Given this list of marker genes ZBTB25, BCKDHB, SLC23A2, HSD3B7, SLC18B1, SIAE, HNRNPA1, ZNF330, REXO2, CSF2, PAQR3, LECT2, TEX261, ST8SIA6, SPTSSA, RTP4, MRFAP1L1 (Morf4 family associated protein 1 like 1), GPR18, SLX4IP, SLC35G1, ZDHHC2, CDC20, PWWP2A, NCOA7, NEU3, BICD1, CSTF2, GJB2, KIF26A, PPM1L, DNAAF10, HNRNPH1, IKZF4, YKT6, DDX31, KRTAP2-4, HCFC2 (NCBI Gene Id 29915), NRTN, NMUR2, AHCYL2, USP31, KCTD5, ZDHHC21, HCN1, KRT72, CACNG5, PRIM2, UHMK1, PUS3, PRICKLE1, AHR, PLRG1, ZNF420, KLHDC8A, ALG1, TWSG1, DNAJC27, E2F1, MTHFD2 (methylenetetrahydrofolate dehydrogenase (NADP+ dependent) 2, methenyltetrahydrofolate cyclohydrolase), CCR5, ADAMTS6, MS4A10, YME1L1, NHLRC1, UBXN2B, GPR83, XXYLT1, COLCA1, NETO2, PPA1, LRPPRC, CALHM2, UBE2V2, CSNK1G3, TVP23B, KLRG1, HOXC4, FAM221A, ZRANB3, TCEAL7, POU2AF2, MEIS1, TRAT1, ZNF483, LIN9, ULK4, TARDBP, ZFP3, FCHSD2, COPA, FCRL1, APPL1, SHE, CCDC6, TMEM245, NAA30, ZNF706, AURKB (NCBI Gene Id 9212), PHTF2, DMD, NAT1, RRAGD, TRUB1, ADRB2 (NCBI Gene Id 154), TMEM181, LIPC, AMPD1, IER5, CDON, GOSR2, CHMP3, MOAP1, AKAP7, IFIT3, CLP1, DACH2, IFIT1, KPNA3, LMBRD1, MAP2K1, PCNX4, MELK, EFHC1, BDH1, AP1G1, ZNF827, RNF121, NOL4, PLEKHA1, PRPS1, CCR7, NUBP2, GMFB, DRC1, MYL10, HNRNPM, FBXO28, TCF12 (transcription factor 12), TTC28, NUP85, RER1, CDH26, UTP15, CYSLTR1, C2orf88, PARD6B, UBFD1, ZC3H15, CD83, SLC22A2, FAM185A, TMLHE, AGO3, SCG2, KCMF1, EHD3, KPNA2, ARMC10, HMGCS2, PENK, SPCS2, MYADM, CD79B (CD79b molecule), RARS1, SOCS2, ST13, FAM72A, PIK3R3, TASP1, ARL4C, CPSF2, APOF, GPR15 (G protein-coupled receptor 15), NARS2, BTG2, GTF2E2, PRRG1, ACTR3B, GZMA, SPMAP2L, DNAAF6, FOXRED1, SAMD7, CWC25, DIPK2A (divergent protein kinase domain 2A), BTRC, MPP7, SOS1, MAT2B, TRIM34, FBXL14, UTP23, ATG12, PON3 (NCBI Gene Id 94886), TUBD1, CHTOP, RASGRF2, GPN1, ATL2, TADA1, here is a description of the gene set: Human Gene Set: GSE25088_CTRL_VS_ROSIGLITAZONE_STIM_MACROPHAGE_UP from publication Szanto A, Balint BL, Nagy ZS, Barta E, Dezso B, Pap A, Szeles L, Poliska S, Oros M, Evans RM, Barak Y, Schwabe J, Nagy L (PMID 21093321) species: Homo sapiens Genes up-regulated in wildtype bone marrow-derived macrophages: control versus treated with rosiglitazone. C57Bl/6 wild-type and STAT6 KO mice were used to study PPARg and IL-4 signaling. Bone marrow of 3 mice per group was isolated and differentiated to macrophages with M-CSF (20 ng/ml). 20 ng/ml IL-4 was used to induce alternative macrophage activation and 1 uM Rosiglitazone (RSG) was used to activate PPARg. From each mouse 4 samples were generated: 1. M-CSF, 2. M-CSF+RSG, 3. IL-4 and 4. IL-4+RSG. All compounds were added throughout the whole differentiation process, and frech media was added every other day. Control cells were treated with vehicle (DMSO:ethanol). After 10 days, RNA was isolated and gene expression profiles were analyzed using Mouse Genome 430 2.0 microarrays from Affymetrix.